Given this list of marker genes Vamp2, Zc3h4, Chst15, Kif3b, Agap3, Sfn, here is a description of the gene set: studied in species Mus musculus Mouse Gene Set: MIR_127_3P Genes predicted to be targets of miRBase v22 microRNA mmu_miR_127_3p in miRDB v6.0 with MirTarget v4 prediction scores > 80 (high confidence targets). from publication Chen Y, Wang X (PMID 31504780)